Given this list of marker genes ATE1OSP, CDH2, MMP9 (matrix metallopeptidase 9), TFAP2A, POT1-AS1, ECI2-DT, CDH1, MIR21, MT-CO2, FN1, GOLGA6L17P, FZD4, LINC02582, LDHA, KIF5B, ZEB2, RAD51-AS1, EP300, MTERF4, HIF1A, MIAT, VCAM1, LINC01089, LINC01361, MYC, PTK2B, HOTAIR, TWIST1, LINC00629, CSF2, MTDH, LINC02245, VIM, MMP2, ATF3, COL1A2, CCR8, VEGFC, NEFL, CD44, STAT1, AK4, LINC00974, PPM1K-DT, ACTA2, PTEN, SLC2A1, LINC00649, BCYRN1, HIPK1-AS1, SNAI1, TEAD4, here is a description of the gene set: species: Homo sapiens Human Gene Set: WP_CCL18_SIGNALING CCL18 signaling